Given this list of marker genes Ipo11, Kpna2rt, Timm10, Xpo1, Dusp16 (NCBI Gene Id 70686), Kpna6, Asf1b, Kpna2, Emc8 (NCBI Gene Id 18117), Vps72, Rbp4, Disp1, Atox1, Pex5, Tnpo2, Hbb-bt, Wrap53, Stard7, Anp32e, Mmgt1, Nubp1, Mtch1, Nutf2-ps1, Emc2 (NCBI Gene Id 66736), Hbq1b, Ccs, Trf, Tcn2, Emc3, Prdm12, Mmadhc, Emc9, Cox18, Nasp, Mb, Hira, Ranbp17, Fxn, Cblif (cobalamin binding intrinsic factor, NCBI Gene Id 14603), Nubp2, Cox17, Nubpl, Urm1, Get3, Hikeshi, Xpo6, Get4, Pcbp2, Nutf2, Ranbp6, Wfs1, Ipo4, Pcbp1, Eif4enif1, Hba-x, Tmco6, Hbb-y, Emc7, Dph3, Zng1 (NCBI Gene Id 226043), Kpna4, Xpo7 (NCBI Gene Id 75101), Spty2d1, Xpo4, Asf1a, Oxa1l, Emc6, Atp7a, Snupn (snurportin 1), Hbq1a, Myd88, Kpna7, Emc4, Hbb-bs, Ngb, Ipo5, Bag6, Xpo5, Kpna1, Hbb-bh1, Hbb-bh2, Nup42, Pwp1, Hbb-bh0, Ndufab1, Sco2, Park7, Ipo9 (NCBI Gene Id 98447), Pex19, Kpna3, Mmaa, Tnpo1, Cse1l, Mtch2, Aplf, Emc10, Clu, Hirip3, Rbp2, Kpnb1, Timm9, Hba-a1, Nap1l1, Calr, Nup214, Emc1 (ER membrane protein complex subunit 1), Ptma, Jdp2, here is a description of the gene set: Directly binding to a specific ion or molecule and delivering it either to an acceptor molecule or to a specific location. studied in species Mus musculus Mouse Gene Set: GOMF_MOLECULAR_CARRIER_ACTIVITY